The following is a description of a gene set: Mouse Gene Set: GOBP_REGULATION_OF_COMPLEMENT_DEPENDENT_CYTOTOXICITY Any process that modulates the frequency, rate or extent of complement-dependent cytotoxicity. species: Mus musculus, and this is the list of marker genes: Il13, Cr1l, Cfh, Cd59b, Hsp90ab1, Cd59a, Cd55, Il4, Cd5l